The following is a description of a gene set: Mouse Gene Set: GOBP_OLIGOSACCHARIDE_BIOSYNTHETIC_PROCESS species: Mus musculus The chemical reactions and pathways resulting in the formation of oligosaccharides, molecules with between two and (about) 20 monosaccharide residues connected by glycosidic linkages., and this is the list of marker genes: Fut2, St3gal2, B4galt1, Sec1, Fut9, B3galnt1, St6galnac1, St6galnac5, St6galnac6, St3gal4, B3galt2, Mpdu1, Mgat2 (mannoside acetylglucosaminyltransferase 2), B3galt1, Lalba, Abo, Fut1